The following is a description of a gene set: species: Homo sapiens Microarray deconvolution is a technique for quantifying the relative abundance of constituent cells in a mixture based on that mixture's microarray signature and the signatures of the purified constituents. It has been applied to yeast and other systems but not to blood samples. Here we test the ability of this technique to determine the fractions of subsets of memory T cells in peripheral blood mononuclear cell (PBMC) samples. from publication Abbas AR, Wolslegel K, Seshasayee D, Modrusan Z, Clark HF (PMID 19568420) Genes down-regulated in comarison of effector memory T cells versus peripheral blood mononuclear cells (PBMC). Human Gene Set: GSE11057_CD4_EFF_MEM_VS_PBMC_DN, and this is the list of marker genes: ANP32A, SESTD1, LTA4H, SNN, DAPP1, CD79A, MXD1, PLOD1, SH2B2 (NCBI Gene Id 10603), CD300LF, DUSP6, FTL, ADAMTSL4, CD300C, SETBP1, PRCP, LGALS2 (galectin 2), PGD, SORT1, KDM1B, TREM1, PEA15, TRPM2, HDAC9, PLSCR1, C15orf39, ASAH1, AATBC, AOAH, DPYD, ZDHHC7, TMEM40 (transmembrane protein 40), RNF130, GBGT1, PIP5K1B, RTN1, NOTCH2, ITGAX, SPRED1, YWHAG, TBC1D8, SLC37A2, KIAA0513, RAB24, BMP2K, GRK3 (NCBI Gene Id 157), UNC93B1, B3GNT5, PLXNB2, CEBPB, PSAP, CD180 (NCBI Gene Id 4064), RAB3D, CD9, CATSPER1, LYST, SLC15A3, BNIP3L, IRAG2, ZNF385A (zinc finger protein 385A), TALDO1, RNASE6, SNAP23, SPTSSA, ATP6V1B2, MFSD1, MEF2A, ARPC3, DAPK1, WDR11, CDK2AP1, NADK, FCGR2C, GRINA, APLP2, CD74, SYK, FMNL2, TRIO, JUP, GAS7, SIGLEC9 (sialic acid binding Ig like lectin 9), ADGRE2, ACRBP, STX7, SPARC, SH2D1B, PTGS1, HLA-DMB, ADA2, IFNGR2, CARD9, TM6SF1, SLC22A15, GLT1D1, LAPTM4A, MACROH2A1 (macroH2A.1 histone), RXRA, ARSB, PDGFC, TPP1, OAZ2, BMP6, NEXN, SCPEP1, GSTP1, NAPSB, TLR2, AQP9, SYT17, TLR4, C9orf72, WDFY4 (WDFY family member 4), ASCL2, ARPC5, NFIL3, HLA-DOA, SPI1 (Spi-1 proto-oncogene), SIGLEC5, MGST1, GNGT2 (G protein subunit gamma transducin 2), HAL, CFD, MS4A7, PCTP (NCBI Gene Id 94001), HK3, SAMD4A, TMEM170B, BLVRB, CRISPLD2, ACER3 (NCBI Gene Id 55331), NAGK, CCDC88A, NME8, FTH1, DYSF, MLC1, BLNK, MTURN, SDCBP, TNFSF13, RNASE2, CORO1C, LYZ, TTYH3, PRKAR2B, ACSL1, EPB41L3, GFOD1, PLEK, TCF4, SLC2A6, INSR, GABARAP, TNFRSF8, PLXNC1, RGS18, FBXL5, CD160, ST20, FNDC3B, JAK2, TP53I3, SRGN, CD244, NFAM1, CTSZ, OAZ1, RAB20, CREG1, SLFN12, ZNF185, TET3, HVCN1, ATP6V0A1, CAT, LINC00968, DGAT2, PDLIM1, PLXDC2, TET2, H2AC6, TKT, RHOQ, LILRB3, ASGR2, ATP6V1A, GPX1, PRKCD, TRAK1, ATP8B4, SLC31A2 (solute carrier family 31 member 2), SLC7A7, PTPRE (NCBI Gene Id 5791)